The following is a description of a gene set: studied in species Homo sapiens from publication Borjesson DL, Kobayashi SD, Whitney AR, Voyich JM, Argue CM, Deleo FR (PMID 15879137) Genes down-regulated in polymorphonuclear leukocytes (12h): control versus infection by A. phagocytophilum. Polymorphonuclear leukocytes (PMNs) were obtained from healthy individuals in accordance with protocols approved by the Institutional Review Board for Human Subjects at the University of Minnesota and the National Institute of Allergy and Infectious Diseases. PMNs (107) were combined on ice with live S. aureus (108) or with live or heat-killed A. phagocytophilum (bacteria isolated from 5x106 infected HL60 cells for a ratio of 1 infected HL60 cell: 2 PMNs, ~ 5-20 A. phagocytophilum: PMN) in wells of a 12-well tissue culture plate (pre-coated with 20% autologous normal human serum). Unstimulated control assays received either buffer (for S. aureus comparisons) or clarified HL60 lysate (for A. phagocytophilum comparisons). Plates were centrifuged at 350 x g for 8 min at 4oC to synchronize phagocytosis and incubated at 37 deg. C in a CO2 incubator for the indicated times. At the indicated times, tissue culture medium was aspirated from the plate and PMNs were lysed directly with RLT buffer (Qiagen, Valencia, CA). Purification of PMN RNA and subsequent preparation of labeled cRNA target was performed as described in Methods. Labeling of samples, hybridization of cRNA with HU133A oligonucleotide arrays (Affymetrix, Santa Clara, CA), and scanning were performed according to standard Affymetrix protocols ( http://www.affymetrix.com/pdf/expression_manual.pdf ). Experiments were performed in triplicate, using PMNs from three healthy individuals for each treatment. Human Gene Set: GSE2405_0H_VS_12H_A_PHAGOCYTOPHILUM_STIM_NEUTROPHIL_DN, and this is the list of marker genes: SIVA1, DCLRE1C, IFTAP, MED18, NMRAL1, AOX1, QSOX2, BUB1B, XIST, ANKS1A, PLXDC1 (plexin domain containing 1), RAG2, CAMK2A, GPT2, ZNF764, PM20D1, ARHGAP11A, PPP1R10, MCUB, PTDSS2, CCNE1, CMSS1, BLM, NIM1K, PDE5A, RCL1, LMNB2, SRR, RTKN2, ALDH1L1, SGO2, KNTC1, INTS1, SLC47A1, CD163, SASS6, CENPE, VANGL2, MAGI3, TRIM32, RTTN (NCBI Gene Id 284278), SMIM13, C4orf54, APCDD1, MAP9, GMNN, LONRF3, CARD10, VAT1, RGS12, GNB1L, ZNF518B, NDE1, RALGPS2, MAD2L1, GLRB, ABL1, PLEKHB1 (NCBI Gene Id 58473), MOAP1, PRIM1, DGCR6, SCNN1A (NCBI Gene Id 6337), NFE2, TTF2, CCDC30, ALS2, SPC25, PIMREG, SHCBP1, PPM1L, TUBE1, ZNF667, CEP128 (centrosomal protein 128), TBL2, MORC1, TEDC1, ALDH1A1, TTC12, KCNH3, B9D2, FANCB, IPP, PRC1, WEE1, HIBADH, BARD1, SLC4A4, ATP10A, PDCD2L, HTRA3, THEMIS, IMPDH2, TRIP13, MNS1, ZMPSTE24, CD27-AS1, TREML4, CPA3, LRRC1, PRR11, ANKRD50, PYCR2, RRM1, RAPGEF5, LIG1, ATAT1, E2F2, CEP70, ABAT, ELP6, CENPP, PAX1, UMODL1, BRIP1, PIGH, CCDC18, SFXN2, BAIAP3 (NCBI Gene Id 8938), ORC6, EPHA3, FAM72A, OIP5, HOXA1, KNSTRN, MASTL (microtubule associated serine/threonine kinase like), KIF20B, GTF2H4, IGF2BP2, FOCAD, SQOR, CNTROB, SLC6A19, TFDP2 (transcription factor Dp-2), ZNF239, ALDH7A1, PRSS23, XRCC6, TBC1D31, CDIN1, PRIM2, TIMM44, DUT, PHETA2, ABCA9, GAS2L3, REEP1, PADI4, MELK, FIRRM, TAF5, SHQ1, ARMC8, CKAP2L, CDC45 (NCBI Gene Id 8319), NUP37, FADS2, INMT, BIRC5, ZDHHC14, ZFYVE21, MYO5C, SHISA6, NPHS2, PTER, DESI1 (desumoylating isopeptidase 1), EFCAB11, GEMIN8, LRRC8E, DNMT3B, L2HGDH, C8orf48, C6orf118, HEMGN, BCAT1, TPX2, IFT56, WDHD1, BSN, TRMT12 (NCBI Gene Id 55039), DCLK2, CLSPN, OSBPL11, ARVCF, TSPAN2, SCN1A, SLCO4A1, AKAP12, MDM1, NUP133, CXCL12, BRMS1L, EDARADD, KIF2C, TENM1, VASH1, PRKAR2B, ZC4H2, OGN, RPAP1